Given this list of marker genes RAD17, H2AX, MRE11 (MRE11 homolog, double strand break repair nuclease), TDP1, HERC2, CDK2, PML, RECQL, TP53BP1, RPA2, UIMC1, BRCA2, MDC1, MCM2, BCL6 (BCL6 transcription repressor), MLH1, PRKDC, PCNA, SEM1, USP1, RPA1, TOPBP1, PLK1, CEP164, MCPH1, BRIP1, FOXM1, TP53, ATR, BRCC3, E2F1, PPM1D, UBE2D3 (ubiquitin conjugating enzyme E2 D3), POLB, WRN, SMARCAL1, FANCD2, SMARCC2, HUS1, ATRIP, PALB2, XPA, BRCA1, MSH2, MDM2, CDC45, BARD1, FANCI, CDK1, RMI1, UPF1, POLN, SMC1A, ATM, EEF1E1, RBBP8, RFWD3, RAD9A, IKBKG, ABRAXAS1, RECQL4, TOP3A, CLK2, PARP1, DCLRE1A, RECQL5, EXO1, CHEK2, SP1, RAD52, XRCC5 (X-ray repair cross complementing 5), RAD1, FANCA, RAD51, CHEK1, FEN1, CDC25C, TRIM28, RAD50, NBN, CLSPN, here is a description of the gene set: Human Gene Set: WP_DNA_IRDAMAGE_AND_CELLULAR_RESPONSE_VIA_ATR DNA IR-damage and cellular response via ATR studied in species Homo sapiens